The following is a description of a gene set: Neurotransmitter clearance Mouse Gene Set: REACTOME_NEUROTRANSMITTER_CLEARANCE studied in species Mus musculus, and this is the list of marker genes: Aldh2, Comt, Slc6a3, Slc6a4, Tomt, Maoa, Slc22a2, Slc22a1 (NCBI Gene Id 20517)